The following is a description of a gene set: studied in species Homo sapiens Hyperactive deep tendon reflexes Human Gene Set: HP_HYPERACTIVE_DEEP_TENDON_REFLEXES, and this is the list of marker genes: RETREG1, SDHD, STUB1, UROC1, SDHB, BEAN1, PRRT2, GALC, SMG9, PRSS12, SDHA, PMP22, TIMM8A, GJA1, PRNP, MAB21L1, ATXN2, PRPS1, ATP6AP2, TANGO2, DNM1L, SDHAF1, ATXN1, SLC2A1, SAMD9L, MECP2 (NCBI Gene Id 8274), KCNC3, MRE11